Given this list of marker genes TGFBR3, MBD5, UNC5C, PTPN13, ROBO2, CMYA5, PTPN14, ANKRD11, UBA6-DT, RERG (RAS like estrogen regulated growth inhibitor), ADAMTS9-AS2, SIK3, P3H2, CACNB2, NLK, PLCE1, TET2, SEPTIN11, CCN2, CERS6, NCOA1, FRMD3, CDK6, IQCJ-SCHIP1, FMN2, BACH1, TJP1, NPNT, ALS2CL, PRKG1, KANK1, CR1, FYN, CEP112, FNDC3B, COL4A4, ACTN4 (NCBI Gene Id 81), RAI14, RNF150, MYO1B, CCDC148, FRY, SRGAP1, CTTNBP2 (cortactin binding protein 2), CPEB4, CAST, ST6GALNAC3, NES, MYO1E, DLG2, PTPRQ, PLXDC2, DACH2, GPC6, SPATS2L, WWOX, PCOLCE2, APBB2, ARHGEF26 (NCBI Gene Id 26084), ZNF804A, VEGFA, ZNRF3, NPAS3, MAML3, SEMA5A, RETREG1, CA10, WIPF3 (WAS/WASL interacting protein family member 3), PODXL, EPB41L5, NEBL, SH3RF1 (SH3 domain containing ring finger 1), ABLIM2, CALD1, SPOCK1, DPP6, XIST, SLC7A8, CTDSPL, FBXL7, CDKN1C, SRGAP2, FMNL2, PTPRO, ENPEP, SGIP1 (NCBI Gene Id 84251), VTI1A, ARMH4, NFASC, LRRC2, ERBIN, DACH1, KIF13A, THSD7A, RBFOX1, GPHN, FAT1, TMEM245, ROCK1, TBC1D1, MTSS1, FGF1, MACF1, PCED1B, CMAHP, ITGB8, UTRN, IQGAP2, CLIC5, BMPR2, MGAT5, HIVEP2, RBMS1, NPHS2, GPX3, ATP10A, MSI2, TANC1, AKT3, KLHL29 (kelch like family member 29), AHNAK, MYO1D, FTX, CPNE8, DST, ANKRD36 (NCBI Gene Id 375248), CRIM1, ERC1, ITGA1, CSPP1, SPOCK2, QKI, EXPH5, SOX6, KIF1B, CCDC91, TEAD1, ANKRD12, TENM3, NTNG1, INTS12, PARD3, ADAMTS19, MAGI2, RYR3, RABGAP1L, KCNQ1OT1, PLA2R1, RASSF8, PAM, GHR, PTPRD, CBLB, PALS1, DYNC2H1, GULP1, MACROD2, PCNX4, SRGAP2C, FCHSD2, KIRREL1, UBE2E2, RDX, BCKDHB, MAGI2-AS3, BICD1, PHACTR4, TENM2, ARHGAP28, ADD3, MYH9, NPHS1 (NCBI Gene Id 8183), CDC14A, GMDS, PDE7B, HTRA1 (HtrA serine peptidase 1), LARGE1, SULF1, SBF2, TARID (NCBI Gene Id 101928164), ITGAV, ZDHHC6 (zinc finger DHHC-type palmitoyltransferase 6), PDLIM5, ARHGEF3 (NCBI Gene Id 50650), DOCK5, EML4, ST3GAL6, SOX2-OT, CPQ, PARD3B, SLK, UACA, MME, DOCK4, MIB1, COL4A3, ARHGEF12 (Rho guanine nucleotide exchange factor 12), KLF7, SSBP2, PTH1R, ZSWIM6, IGF1R, PICALM, LUC7L3, PAN3, PAWR, ADAMTS9, EEA1, PSD3, GOLIM4, SPAG16, PALLD, here is a description of the gene set: species: Homo sapiens Human Gene Set: LAKE_ADULT_KIDNEY_C2_PODOCYTES from publication Lake BB, Chen S, Hoshi M, Plongthongkum N, Salamon D, Knoten A, Vijayan A, Venkatesh R, Kim EH, Gao D, Gaut J, Zhang K, Jain S (PMID 31249312)